Given this list of marker genes Col6a1, Abca8a, Gm14335, Hic1, Tceanc, Sfxn4, A830012C17Rik, Ogn, Col14a1, Gzmk, Npffr1, Agtr2, Medag, Fam227b, Adamtsl3, 4631405J19Rik, Gas2, Smoc2, Gm16263, Phf1, Trpm5, Igf1, Il33, Tle2, Mfap5, Smarca2, Ccn3, Scara5, Prrt2, Angptl1, Glt8d2, Vmn2r3 (vomeronasal 2, receptor 3), Amot, Tpcn2, Fbln5, Gm45844, Fibin, Phex, Egfl6, Ltbp3, Pamr1, Col6a3, Pcdhga1, Kif17, Rxfp2, Abi3bp, Kera, Col16a1, Adamtsl5, Zcwpw1, Arsj, Otor, Col6a6, Fgf7, Gpr83, Slc22a22, Gm22205, Gm12963, Lhfpl1 (NCBI Gene Id 237091), Aspn, Naalad2, Adam33, Adgrd1, Col6a2, Ccdc107, here is a description of the gene set: Mouse Organogenesis Cell Atlas (MOCA) DE_gene_main_cluster.csv, fold.change>=1.5, qval<0.05, pval<0.05 species: Mus musculus from publication Cao J, Spielmann M, Qiu X, Huang X, Ibrahim DM, Hill AJ, Zhang F, Mundlos S, Christiansen L, Steemers FJ, Trapnell C, Shendure J (PMID 30787437) Mouse Gene Set: DESCARTES_ORGANOGENESIS_CONNECTIVE_TISSUE_PROGENITOR